Given this list of marker genes NLGN1, CRH, LINC02210-CRHR1, PRKCB, PLEK, HTR1A, HTR2C, HTR2A, PLCD4, PPP3CA, FOS, ARC, CRHR1, GRIN2D, here is a description of the gene set: Serotonin and anxiety-related events Human Gene Set: WP_SEROTONIN_AND_ANXIETYRELATED_EVENTS studied in species Homo sapiens